The following is a description of a gene set: Mouse Gene Set: GOCC_PLASMA_MEMBRANE_RAFT studied in species Mus musculus A membrane raft that is part of the plasma membrane., and this is the list of marker genes: Chrnb2, Itgb2l (NCBI Gene Id 75978), Ctsb, Adrb2, Cd8a, Gask1a, Nos3, Irs1, Lrp6, Ezr, Ms4a1, Chrna3, Pacsin2, Tex101, Mlc1, Slc27a1, Atp1a2, Fxyd1, Mapk3, Pld2, Atp1b1, Plpp1, Smpd2 (sphingomyelin phosphodiesterase 2, neutral), Hdac6, Itgam, Cntnap2, Prkar1a, Scn5a, Asah2, Lrrk2, Mal (myelin and lymphocyte protein, T cell differentiation protein), Emp2, Lcp2, Plvap, Calhm1, Slc5a7, Sele, Neu3, P2ry12, Adra1a, Lypd4, Bves, Tgfbr1, Nos1, Tfpi, Myof, Lypd11 (Ly6/PLAUR domain containing 11), Sorbs1, Dlc1, Erbb4, Lrp4, Kcnd2, Adcy8, Grk2, Flot2, Cav1, Rangrf, Cbl, Jak2, Dag1, Insr, Chrna7, F2r, Lypd10, Cr1l, Ptch1, Gnaq, Kif18a, Atp1a1, Slc2a1, Cavin4, Myo1a, Flot1 (NCBI Gene Id 14251), Hmox1, Adra1b, Cavin1, Cav2, Itgb2, Cdh15, Cdh2, Vdr, Ctnna1, Ehd2, Lrp8, Ptgs2, Drd1, Slc2a3 (solute carrier family 2 (facilitated glucose transporter), member 3), Cln3, Cd177, Hck, Ptgis, Add2, Lipe, Entpd1, Trem2, Selplg, Cavin3, Cavin2, Src, Cdh13, Cav3, Htr2a, Ms4a4a, Kcnd3, Nos1ap (nitric oxide synthase 1 (neuronal) adaptor protein), Trpm8, Scarb1, Spred1, Cacna1h, Igf1r, Cacna1c, Mapk1, Coro1c, Ldlr, Cdh1, Prkaca, Prtn3, Kcnma1, Stim1, Prkar2a, Ptpn11, Fasl, Akap6, Adtrp, Atp1b3, Aqp1, Slc22a6, Slc6a3, Tsc2, Cd36, Hk1, Bmpr1a, Orai1, Tgfbr2, Skap1, Has2, Adcyap1r1 (adenylate cyclase activating polypeptide 1 receptor 1), Efna5, Trpc4, Myo1d, Plpp2, Ctnnb1, Ctnnd1, Smo (smoothened, frizzled class receptor), Bmpr2